Given this list of marker genes CKMT1A, CKMT1B, CKM, CKMT2, CKB (creatine kinase B), here is a description of the gene set: The chemical reactions and pathways involving phosphagen, any of a group of guanidine phosphates that occur in muscle and can be used to regenerate ATP from ADP during muscular contraction. Human Gene Set: GOBP_PHOSPHAGEN_METABOLIC_PROCESS species: Homo sapiens